The following is a description of a gene set: from publication Chen Y, Wang X (PMID 31504780) Genes predicted to be targets of miRBase v22 microRNA hsa-miR-3180-5p in miRDB v6.0 with MirTarget v4 prediction scores > 80 (high confidence targets). studied in species Homo sapiens Human Gene Set: MIR3180_5P, and this is the list of marker genes: FSCN1, PFN2, RYR2, GSPT1, KLF5, VASH2, KLHL13, TRIM7, PPM1H, STIM2, DHX15, PVALB, ZBTB34, NAB1, RNF185, C2orf68, ARGLU1, P2RY1, CHMP1B, SPTSSB, GLIS1, LRRC8B, FAM180A, ARHGEF12, FLNB, ZDHHC21, BACH2, ATP1B4, TK2, HOXD10, PSD3, GDI2, TNFRSF1A, WDR5, BACE2, TNFRSF10B, MYO5A, E2F7, POLDIP3, ATAD2B, ACTR2, PLCE1, KCNA4, WNK3, GABRA4, ESRRB (NCBI Gene Id 246148), DIRAS2, KCNH1, RFESD, CDC73, PLEKHA5, ARFRP1, PRDM10, LHX8, KPNA1, PAPLN, ABCD2, TMEM132B, ATRNL1, AREL1, PAPPA, SECISBP2 (NCBI Gene Id 79048), SP4, CCDC3, GABARAPL2, ASB2, CERS6, B4GALT5, SLC25A24, PDE12, COX5A, NUCB1, AMOTL1, COLQ, TAF4B, TP53INP1, TGFB3, ICE1, HTR2A, KIF2A (kinesin family member 2A), KLHDC10 (NCBI Gene Id 23008), FZD4, ANO5, CASP7, FKTN, PEX12, PHF20L1, ITSN1, IDI1, RBM15, PAGE2B, KREMEN1, STRADB, WIZ, TENM4, SLC25A27, FBXO4, RASGRP1 (RAS guanyl releasing protein 1), HAUS4, LVRN, RGS6, CHN2, TNFRSF21, TMEM263, LEAP2, TMEM33, PRR15, CDK13, DTNA, CD44, DTD1, ITPRIPL2 (ITPRIP like 2), HHEX, SLC7A10 (solute carrier family 7 member 10), NXPH1, NEXMIF, AEBP2, RHOU, NAV1, ARSB, NDUFB6, ATPSCKMT, SLC30A5, NEGR1, SYCP1, THOC2, NIPAL4, PCSK6, ZMAT1, CMTR2, NXT1, RASSF5, RGS4, TULP4, RHBDD1 (rhomboid domain containing 1), HYCC1, TENM3, PADI2, C5orf47 (NCBI Gene Id 133491), ONECUT2, IL5RA, SLC16A9, QRSL1, TANC2, HSF5, NBR1, HAPSTR1, RPF2, SRPRB, NMT2, SEL1L, HECW2, CD86, INTS7, SMARCA5, SLC30A7, ARFGEF2, UBE2Q1, ETNK1, BAGE2, KATNBL1, SESN1, SCD, LRRC28, ITCH, JPH1 (NCBI Gene Id 56704), CRKL, SPOCK1, CSTF2, KCNJ13, PLCL2, PDIK1L, TXK, LARP1B, RNF212B, ZC3H12C, FXR1, HLA-DQB1, RPL22, RAB21, USP16, BTG1, LHX6, CSN2, SASS6, SEMA3A, ADAMTS5, KALRN, RIMS1, CDKL2, CCDC186, FBXO28, KLF9, TNRC6B, SCFD2, ACER2, SHE, SNRK, TSPAN2, TOPORS, PPP3CA, SRC, TTLL7, HEG1 (heart development protein with EGF like domains 1), CACTIN, BNIP3 (NCBI Gene Id 664), RC3H1, ABAT, FAM32A, NOL9, TCF20, TMEM267, SLC1A2, PDCD6IP, TTPAL, UNC5CL, CILP, SNTB2, TTC7A, VPS53, ABHD17B, COX4I1, CPSF2, ADCY1, NPY2R, ANXA11, SCAI, SPSB4, KIF21A, SGMS1, HTR2C, PLA2G12B, SLC35D1, NAP1L1, AGAP1, ZFHX4, ALDOB, PAGE2, SNX7, UBQLN1, HIPK3, RAB23, CHERP, CNBP, OLR1, IRS1, P2RY14, AK3, STK40, REV3L, CD36, TXNDC8, CUX2, DYNC2LI1, PRKG1 (NCBI Gene Id 5592), TENT5D, LDAH, CCDC88C, LSM8 (LSM8 homolog, U6 small nuclear RNA associated), IL1A, NOX4 (NCBI Gene Id 50507), STX2, FAM135A, IFT80, SEMA7A, CCDC12, GIPC3, ZNF641, SENP2, CTNNA3, PBX1, TM4SF18, SRPK2, MAP3K13, SNAP29, PTPRB, ADCY2, NUFIP2 (nuclear FMR1 interacting protein 2), NEDD9, CHCHD7, FAH, MAMDC2, BCL3, ABCG2, USP5, USF3, MORF4L1, ZNF623, OGT, TNKS2, CDH19, SEC22A, CPEB3, ABTB2, PDCD4, SFMBT1, CFAP20, S1PR3, EIF3A, SGIP1, PTPN12, RBM24, ABHD2, EID1, KCNJ3, ZSCAN31, ADD3 (NCBI Gene Id 121)